Given this list of marker genes GABRB2, MIR99AHG, TRAP1, HIRIP3, PARG (NCBI Gene Id 95267), E2F8, DPEP3, TSPAN5, GNRHR2, ZNF624, PRKAG2-AS1, SLC4A10 (solute carrier family 4 member 10), BASP1-AS1, ENSG00000280119, SYNC, MTFP1 (NCBI Gene Id 53596), SLC25A1, SDHAP1, PLCXD3, FBXL12, EIF2B2, TMEM72, TBX5-AS1, ABCA9, EPYC, ADAM20, GREB1L, OBSCN-AS1, ZNF354C, OLIG2, IRF4, KRTAP4-6, GULP1, AP1S3, ZNF544, MT1E, MTERF1, ZNF138, SLC1A7, DRD2, ELMOD1, OR10D3, ME1, DEPTOR, TRAF3IP2-AS1, BICC1, EDA2R, ZBTB24, TTTY5, NPY2R, NRAD1, PTHLH, OR1J4, MED22, CDCA8, CLDN20, CABP2, RIPPLY1, ERICH6, DHRS4-AS1 (DHRS4 antisense RNA 1, NCBI Gene Id 55449), GBP6, STON1, PKP3, CD28, ZNF208, STRBP, GOLGA1, POU3F2, B3GALT2, DDC-AS1, PCA3, HHIP-AS1, SCAND2P, ZNF485, SLC38A4, HOXA11, PHAX, SPRR4, HERC2P1, GLDC, THRA, RPAP3, KCNA4, CPO, C4BPB, NCAM2, ADGRA1, PLK4, CTLA4, KRTAP2-4, CMTM4, DNAI3, PKLR, CABYR, CFHR4, DOP1B, BNIP1, TLR5, CYP4A11, RIC3, ZNF789, A2M, BMX, RAD21L1, RUSC1-AS1, ERCC6L, STATH, NAV2-AS5, CARINH, MYL5 (myosin light chain 5), LINC00841, CGN, YAP1, LARP6, LINC01783, ZNF320, SCNN1B, SERPINB13, ATP11A-AS1, DRAXIN, MAGEH1, TSBP1, TESPA1, MGC4859, KIF18A, C12orf75, SPRYD3, LRRC31, ARHGAP20, MFF-DT, ENSG00000248540, TATDN3, KCND3, NXPH2, ANKRD29, KRT72, RAG1, UPK1A, CIBAR1-DT, OR10C1, PCDHGB8P, PRICKLE2, HTR3C, SLCO2A1, TTC22, ZACN, STYK1 (NCBI Gene Id 55359), CABS1, WBP2NL, ANKRD26P3 (NCBI Gene Id 100101938), TMEM225, TBXT, CPLANE1, GAS6-DT, SEMA4F, TAFA5, ZNF28, PBX1, DIAPH3, LINC00470, TACC2, DNAI4, KCNJ6, AJUBA, PCDHGB6, HLA-DPB2, MYOC, WNT2, FBXO16, ODAPH, TRMT61B, LINC00645, HMGB3P22, IGSF11, LINC01346, PALS2, FKBP4, KLHL3, GSTM5, OR7A5, KRTAP19-3, RASSF8-AS1, ZNF204P, CHRM4, FANCI, TUBB4A, LAMP5, PTPN5, GTF2H2, CNKSR2, VTCN1, AMPH, GPR19, here is a description of the gene set: studied in species Homo sapiens Human Gene Set: GSE9988_LPS_VS_LOW_LPS_MONOCYTE_UP TREM-1 is an orphan immunoreceptor expressed on monocytes, macrophages, and neutrophils. TREM-1 associates with and signals via the adapter protein DAP12/TYROBP, which contains an immunoreceptor tyrosine-based activation motif (ITAM). TREM-1 activation by receptor cross-linking is pro-inflammatory, and can amplify cellular responses to Toll-like receptor (TLR) ligands such as bacterial lipopolysaccharide (LPS). To investigate the cellular consequences of TREM-1 activation, we have characterized global gene expression changes in human monocytes in response to TREM-1 cross-linking in comparison to and combined with LPS. Both TREM-1 activation and LPS up-regulate chemokines, cytokines, matrix metalloproteases, and PTGS/COX2, consistent with a core inflammatory response. However, other immunomodulatory factors are selectively induced, including SPP1 and CSF1 (i.e., M-CSF) by TREM-1 activation and IL-23 and CSF3 (i.e., G-CSF) by LPS. Additionally, cross-talk between TREM-1 activation and LPS occurs on multiple levels. While synergy in GM-CSF protein production is reflected in commensurate mRNA abundance, comparable synergy in IL-1b protein production is not. TREM-1 activation also attenuates the induction of some LPS target genes, including those that encode IL-12 cytokine family subunits. Whereas positive TREM-1 outputs are abolished by the PI3K inhibitor wortmannin, this attenuation is largely PI3K-independent. These experiments provide a detailed analysis of the cellular consequences of TREM-1 activation, and highlight some of the complexity in signal integration between ITAM- and TLR-mediated signaling. from publication Dower K, Ellis DK, Saraf K, Jelinsky SA, Lin LL (PMID 18292579) Genes up-regulated in comparison of monocytes treated with 5000 ng/ml LPS (TLR4 agonist) versus those treated with 1 ng/ml LPS (TLR4 agonist).